Given this list of marker genes Adora2a, Ghrl, Ptgds, Adrb1, Gabrb3, Ada, Atp1a3, Per3, Adora1 (adenosine A1 receptor), Hcrt, Chrnb2, Ptger3, Btbd9, Ptger4 (NCBI Gene Id 19219), Uts2, Gla, Npy2r (neuropeptide Y receptor Y2), Il18, Drd1, Casp1, Parp1, Kcna2, Fxr1 (NCBI Gene Id 99741), Ghrhr, Drd3, Ghrh, Ptgdr, Mtnr1b, Il6, Cort, Nmu, Cacna1i, Pln, Grin2a, Uts2r, Drd2, Csf2, Alb, Pmch, here is a description of the gene set: Any process in which an organism enters and maintains a periodic, readily reversible state of reduced awareness and metabolic activity. Usually accompanied by physical relaxation, the onset of sleep in humans and other mammals is marked by a change in the electrical activity of the brain. Mouse Gene Set: GOBP_SLEEP species: Mus musculus